The following is a description of a gene set: Genes having at least one occurence of the motif CAGCTTT in their 3' untranslated region. The motif represents putative target (that is, seed match) of human mature miRNA hsa-miR-320 (v7.1 miRBase). Human Gene Set: CAGCTTT_MIR320 species: Homo sapiens, and this is the list of marker genes: NPAS2, SMAP1, FTL, FAM117B, PPP1R16B, TFE3, SEC31B, MLLT3, CLASP1, SDHC, RHOBTB1, IGF2BP3, KLHDC9, PCDHA1, SH3RF1, MXI1, CREB5, HIPK1, GABPB2, PCDHA5, XPO1 (exportin 1), NEGR1, PCGF3, AFF4, HDAC4, QKI, ZNF652 (NCBI Gene Id 22834), AP3M1, SHISA7, NAP1L5 (NCBI Gene Id 266812), EIF3J, TWF1, AMBN, DSCAM, ABHD13, CDH2, INA, YES1, PAN3, PPM1B, PCDHA7, SELENOF, SRSF7, IGF1R, DTNA (dystrobrevin alpha), DAZAP1, CTNNB1, PCDHA10, TAC3, USP20, TOMM70, YWHAZ, ESRRG, KLF5, CALN1, ABCA12, TMEM106B, DPY30, PCDHAC1, TPD52L2, CAB39, TMEM47 (transmembrane protein 47), TMEM9B, SPRED2, USP25, PCDHA6, CUX1, NSD2, PCDHA3, BTBD3, HECTD2, MAPK1, PCDHA8, KCNH7, PBX3, RBM45, KLF13, FLRT3, MEX3B, SATB2, CEMIP2, PPP2R5B, PAK5, ULK1, SLITRK3, MECP2, CRYBG1, PCDHA13, FKBP1A, CDK6, GSPT1, BANP, TMEM255A, DHX15, MMP16, ING5, YWHAQ, MCL1, YTHDF3 (YTH N6-methyladenosine RNA binding protein F3), SPOPL (NCBI Gene Id 339745), COPS2, SLC10A3, CACNA1E (NCBI Gene Id 777), DCUN1D3 (defective in cullin neddylation 1 domain containing 3), BAHD1, POGZ, SERBP1, ELL2, TRIM41, SMCR8, ZFP91, FOXN3, PPP2R2C, PCDHA4, PALLD, RAP1A, MTDH, ADAM10, EEF1AKMT2, MSI2, ICA1, IPO7, CAMTA1, WRNIP1, EREG, ARHGAP44, RASA1, CALM3, TRAF7, OGT, AZIN1, PCDHAC2, RBMS3, ZNF3, NONO, ARPC5, ZNF280C, ARPP19, MAPK8IP3, GPBP1, PHF1 (NCBI Gene Id 5252, PHD finger protein 1), FHIP2A, CDK13, TMEM108, RUNX1, GRB2, CDH20, CNOT7, DNER, RAP2C, NEXMIF, CAMSAP2, FBXO11, RBFOX1, SEMA6D, STAG2, PCDHA12, KLHL36, NR4A2, HOXB4, BHLHE40, PURB (purine rich element binding protein B), SMG7, ATRX, CYRIB, ARMCX2, GSPT2, ATG14, ENAH, TSC22D3, YWHAE, RAB18, CALD1, RAI2, KCNS3, ADGRL1, TNRC6B, PCDHA2, MN1, MAT2A, TLK2 (NCBI Gene Id 11011), MUC13, VPS37B, SPCS2 (NCBI Gene Id 9789), LMO3 (NCBI Gene Id 55885), DAB2, UBE2D3, LRCH2, RO60, PCSK7, HSPB6 (heat shock protein family B (small) member 6), ATXN1, PHF8, PLXNC1, CPEB1, PHOX2B, DHDDS, DBN1, TBL1XR1, MIER1, GCNT4, DAG1, TRMU, TSPYL5, SPTSSA, CREBRF, DERPC, MIER3, NRP1, FOXQ1, METTL16, EYA4, TFRC, ARL8B, PPM1A, ANKRD13A, ZIC3, BMPR1A, PCDH19, POLE4, PLAG1, EMC7, DHX30, HELZ, PLK2, RAD18, RHOG, NSRP1, TDG, KMT5B, NCDN, KDM5A, SON, HIVEP2, TNFRSF21, PCDHA9, TAF5, PPARGC1A, PLPPR1, ZNF281, HNRNPC, PLK3, MRPS25 (NCBI Gene Id 64950), ZC3H7B, N4BP1, ATP6V1A, LUC7L2, UNC5A, TSC1, ARID5B, RAD9A, TPM3, PCDHA11, SOBP